The following is a description of a gene set: Mouse Gene Set: GOBP_NEGATIVE_REGULATION_OF_RETINOIC_ACID_RECEPTOR_SIGNALING_PATHWAY Any process that stops, prevents, or reduces the frequency, rate or extent of retinoic acid receptor signaling pathway activity. species: Mus musculus, and this is the list of marker genes: Ezh2, Cnot1, Calr, Dhrs3, Cyp26b1 (cytochrome P450, family 26, subfamily b, polypeptide 1), Tgif1, Zfp536